The following is a description of a gene set: from publication Nakaya HI, Wrammert J, Lee EK, Racioppi L, Marie-Kunze S, Haining WN, Means AR, Kasturi SP, Khan N, Li GM, McCausland M, Kanchan V, Kokko KE, Li S, Elbein R, Mehta AK, Aderem A, Subbarao K, Ahmed R, Pulendran B (PMID 21743478) Genes down-regulated in peripheral blood mononuclear cell 3d vs 0d in adults (18-50) after exposure to FluMist, time point 3D. Comment: Supplementary Table 1b: All the differentially expressed genes identified in PBMCs of TIV vaccinees. species: Homo sapiens Human Gene Set: NAKAYA_PBMC_FLUMIST_AGE_18_50YO_3DY_DN Here we have used a systems biology approach to study innate and adaptive responses to vaccination against influenza in humans during three consecutive influenza seasons. We studied healthy adults vaccinated with trivalent inactivated influenza vaccine (TIV) or live attenuated influenza vaccine (LAIV). TIV induced higher antibody titers and more plasmablasts than LAIV did. In subjects vaccinated with TIV, early molecular signatures correlated with and could be used to accurately predict later antibody titers in two independent trials. Notably, expression of the kinase CaMKIV at day 3 was inversely correlated with later antibody titers. Vaccination of CaMKIV-deficient mice with TIV induced enhanced antigen-specific antibody titers, which demonstrated an unappreciated role for CaMKIV in the regulation of antibody responses. Thus, systems approaches can be used to predict immunogenicity and provide new mechanistic insights about vaccines., and this is the list of marker genes: CDK12, EIF3A, PRPF3, THBS1, ZNF184, SLC12A6, KDM5C, MED13, DIP2B, ZFP36L1, IRAG2, ZNF746, GNAI3, RNF19A, SC5D, PSIP1, GSK3B, GJB6, TOP1, UNK (NCBI Gene Id 85451), RMND5A, GNA13, CDC37L1, ZNF430, PRKCH, ISCA1, LMNA, CHD2, ATP2B1, MAFF, HIPK1 (NCBI Gene Id 23323), CNOT6L, RAF1, IFNGR1, POLB, EIF4E, KDM3A, SUMO1, TRIM23, TMEM39A, SLC9A8, FBXO45, PIK3R1, SREK1, FOXO3, PDCD4, POM121, ZEB1, GALNT3, PDS5A, RMC1, CCNL1, CD69, DHX40, BHLHE40, OPA1, LRPAP1, JUND, SPATA13, PPFIBP1, MCTP2, CYLD, RAB30, PDXDC1, LONRF3, RHBDD2, NDUFV2, CASS4, DUSP4, RGCC, NRBF2, TVP23B (NCBI Gene Id 51030), PNO1, THUMPD3, MLF2, CSNK1D, CLK1, TXNDC11, PPM1D, OGA, MAF, PPP4R1, FBXO16, CWC25, FBXO21, NUP50, DIS3, PPP1R3B, NUP54, PLCL1, TMX4, LUC7L2, TAB3, PTBP2, OSBP, ATOSA, B3GNT2, MED14, BMAL1, MED23, NR1D2, RNF10, FBXL3, LCOR, RNMT, EZH2 (NCBI Gene Id 392834), PJA2, PKN2, POM121C, RO60, PDE12, TRIM59, TIGAR, GTPBP1, RELA, NDUFAF7, MIS12, ZFR, NDE1, NET1, WAC, NTMT1, BAZ2A, CEBPB, CAPZA1 (capping actin protein of muscle Z-line subunit alpha 1), ZNF12, JMY, TNFAIP3, FOSL2, BRPF3, ARIH1, EP300, BORA, KDM6B, CTDSP2, USP16 (NCBI Gene Id 10600), BACH2, GRK2, PGS1, EDRF1, KIF1B, GPCPD1, BOD1L1, RHOH, HNRNPH3, CREBRF (NCBI Gene Id 153222), CDC42, ADNP2 (NCBI Gene Id 22850), H1-2, SON, HSPA14, SFSWAP, ZBTB11, CBX4, ITM2A, ZFP1, MRPS22, SFPQ, PHF5A, MAP4K4, RB1CC1, TSPYL2, PRELID3B, NDFIP1, VCP (valosin containing protein), DPP8, PIK3C2A, CISD2, STK35, CCDC66, PPP4R2, WDR26, SCML1 (NCBI Gene Id 6322), LYSMD3, ERO1B (endoplasmic reticulum oxidoreductase 1 beta), MSI2, PPM1A, NAP1L5, ARPP19, SAP130, RAE1, RPS6KA5, TTC39B (tetratricopeptide repeat domain 39B), GKAP1, PDK1, CDK11A, KBTBD2, ZNF805, TP53INP2, CEBPZ, SENP2, RBBP6, CDS2, TBC1D15, RNF38, FAM169A, CHORDC1, ATXN7, BOLA2, PATL1, KPNA4, RAB18, RYK, PBXIP1, PIK3CA, WDR48, SESN2, PIGB, FOXP1, ZHX1, RTN4, FRYL, BRAP, SCAF8, ZNF451, ZFC3H1, SPATA2L, CANT1, TFAM, PTP4A1, KLHL24, CASP3, FAM76B (NCBI Gene Id 143684), ZNF131, OTUD5, DDX20, RARA, SLC25A37, ZBTB44, GPRASP1 (NCBI Gene Id 9737), NXT1, PSPC1, PRMT9 (protein arginine methyltransferase 9), BCCIP, ZNF317 (zinc finger protein 317), CWF19L2, ATAD2, FAM168B, S1PR1, LRRC8C, CDR2, JOSD1, NUFIP1, ATL2, BCLAF1, ZDHHC18, ARID4A, PPP2CA, H2AC18, ARIH2, CENPU, CLK4, ATXN1, TGS1, MARF1, DICER1, RIF1, MIER1, SPAG9, DNAJA1, ZFYVE27, DCP1A, YES1, HIVEP1, RBM39, PRXL2C, DDA1, NAP1L3, DENND4A, XCL1, JAG1, ZNF211, H2AZ2, CD28, PPIL4, CHST11, FOXO1, PPP6C, TMEM170A, ZC3H12A, TRMO, ZNF507 (zinc finger protein 507), GGNBP2, ELOVL5, WIPF2, POLR2D, FGFR1, RANBP2, PHF20L1, SMC4, IVNS1ABP, INO80D, SECISBP2L, EXOSC9, AHCTF1, RELB, TMCC3, TENT4B, TNIK, PPP1CB, WIPF1, TCP11L2, PLCXD2, ZNF791, TIMM23, DLEU2, DERL1, RICTOR, CGRRF1, PLK3, IRF2BP2, CRY1, KLHL9, SAMD4B, SNX13, PDE4D, SLC25A28, EPC1, PHF3, SENP5, LITAF, CDK17, ERMN, PMAIP1, PRKAA1, GCNT7, ZNF395, SLAIN2, DOCK4, PDZD8, CUL3, AFF4, YKT6, SNX9, ANGEL2, SLAIN1 (SLAIN motif family member 1), PNPLA8, MTFP1, COPS8, DHX8, METAP2, GABARAPL1, TACC1, ABHD13, PGRMC2, ATG14, KPNA5, RNF103, UBE2B, CCNT1, MBNL2, CD44, GALC, LRP10, CSNK1E, FUBP3, LINC-PINT, MIER3, RIOK1, GMNN, H2AC19, DENND6A, SYS1, SINHCAF, SFN (NCBI Gene Id 2810), MARCHF6, PNISR, DCTN4, RLIG1, POLR1F, CCDC186, RGPD6, AP1G1, WWP2, MIDN, WBP11, RETREG2, STAM, NFKBID, CDK7, PI4K2A, NAF1, GPRIN3, KDM5B (NCBI Gene Id 10765), QSOX1, CCNH, FNBP4, GPR132, KPNA3, CDC73, MCM9, ELK4, OSGIN2, SVIP, ARMCX5 (NCBI Gene Id 64860), KLF3, NFKBIB, UBL3, APPL2, SPTAN1, MCM6, UFM1, ASB6, PELI2, TAF9B, MZT1, MED21, ZNF274, SLC35D1, H2BC4, NOP58, TMEM135, TRAPPC10, VIRMA, METTL16, ZNF136, GRPEL2, ZNF518B, ZNF708, SMAD7, SF3B1, SIK3, CHD1 (chromodomain helicase DNA binding protein 1), KDM6A, HABP4, SEPSECS, ZDBF2, PPP1R16B, PAFAH1B2 (platelet activating factor acetylhydrolase 1b catalytic subunit 2), SYTL3, BBX, BRWD1, PTS, MAK16, FKBP11, EIF4G3, PHC1, IGF1R, ATP11B, ALKBH5, MKNK2, DHRS13, MPZL3, METRNL, RAB11FIP2, CSNK1A1, TBRG1, PCIF1, TWF1, AP3M2, SMN1, TAF1D, FAM209B (NCBI Gene Id 388799), KCTD2, DNAJB1, ELL2, PIP4P1, RGPD5, HYCC2, PDXDC2P, CFAP20, FAM210B, G2E3, PDIA3, ZFX, SIPA1L1, TMPO, GNAS, NCOA1, TXNL1, MYNN, TFB2M, ZRANB1, ATP6V1H, RFC1, ST7, RORA, PPP3R1, EMSY (NCBI Gene Id 56946), ZNF644, THUMPD2, MYLIP, PPM1B, EML4, ARAF, DDX24 (DEAD-box helicase 24, NCBI Gene Id 57062), MAP3K2, ZNF24, SAR1A, RNF19B, FASTKD2, ARL4C, RALGAPA2, UBN1, TMEM41B, STXBP5, FOXN3, ZBTB2, FBXO3, ABHD5, BSDC1, DNAJB6, RUNX3, CYP4F3, SELENOI, SURF4, EZR, NDUFAF5, ENC1 (ectodermal-neural cortex 1), JARID2, RBM27, YTHDC1, ANKRD28, CAMK4, CD59, RBM38, ANKDD1A, MSL2, CENPC, RPS6KB1, IGKV1-16, STK17A, AKAP8, ABTB3, PHF10, ANKRD33B, KIF25, SPOCK2, IMPA1, MTERF4, HOOK1, DNAJC27, ZFP91, BLTP3B (bridge-like lipid transfer protein family member 3B), IFRD1, PAIP1, USP36, PHF1, NMD3, SUPV3L1, MME, KAT6A, USP38, ATG16L1, PRDM2, HNRNPL, NSMAF, SLC26A6, AREL1, TFG, EMC7, CNST, SORL1, RAPGEF2, TBC1D23, RBM12, PLAA (phospholipase A2 activating protein), BTG3, CLTB, SERINC1 (NCBI Gene Id 57515), UBXN6, ARID3B, CIR1, ZNF410, HSPA9, STAG1, PURB, CRY2, FAF2, DENND1B, FAM209A, RCOR3, RASA2, C14orf28, SYAP1, POLR3E, BCR, VEGFA, CEP95, KIF5B, SLC25A36, RBM33, MAPKAPK2, SFXN1, BRD1, PDK3, HNRNPC, RBM26, HNRNPD, ZNF567, SMN2, HBP1, RRN3, TPCN2, RGPD8 (NCBI Gene Id 727851), CWF19L1, DDIT4, DNAJC2, TPP2, MBIP, ZNF292, PPP4R3A, RRP12, RSBN1, CUL2, MGAT5, SEC22C, CHIC2, EIF2AK3, HERC3, TFIP11, EBLN2, ARMC8 (armadillo repeat containing 8), ESS2, STAMBPL1, HIC1, RAMAC, PIGA, PER1, ADAM8, HAPSTR1, ZC3H15, ESCO1, HMCES, WTAP, CAND1, NEDD1, NUP153, LEPROTL1, NFRKB, TSC22D2, FUBP1, CUL4A, WASL, ARAP3, SUCO, RELL1, PDP1, PPP2R5C, CSNK1G3, NUP160, RNF125, CLDND1, SIRT1, TMF1, FGFR1OP2 (NCBI Gene Id 378428), SNW1, TBC1D25 (TBC1 domain family member 25), PHACTR1, GOLGA4, WDR33, LATS2, BRD7, LRRFIP1, JMJD1C, STT3B, PSME4, RPS27, RC3H1, GATA3, MEGF6, ABCA1, MCPH1, RAB8B, KRAS, UBAP2L, MAP1LC3B, TEX30, METTL14, TFDP2, HIC2, CHD7, IDS, FUT8, HEXA, JAK1, GIGYF2, HMGXB4, BCL7B, USP42